Given this list of marker genes TREM2, E2F3, PPARD, PER2, FGF10, TFDP1, E2F1, PID1, FTO, VSTM2A, here is a description of the gene set: Any process that modulates the frequency, rate or extent of fat cell proliferation. studied in species Homo sapiens Human Gene Set: GOBP_REGULATION_OF_FAT_CELL_PROLIFERATION